The following is a description of a gene set: Mouse Gene Set: GOBP_NUCLEOLUS_ORGANIZATION studied in species Mus musculus A process that is carried out at the cellular level which results in the assembly, arrangement of constituent parts, or disassembly of the nucleolus., and this is the list of marker genes: Sirt2, Nolc1, Zfp354a, Baz2a, Suv39h1, Rrp8 (NCBI Gene Id 70389), Bend3, Smarca5, Phf2, Rrn3, Emg1, Ddx11, Pes1, Polr1b, Phf8, Usp36, Actr6, Sirt1, Rps19